The following is a description of a gene set: Human Gene Set: REACTOME_ATTACHMENT_AND_ENTRY studied in species Homo sapiens Attachment and Entry, and this is the list of marker genes: SDC4, CTSL, TMPRSS2, NRP1, GPC3, HAVCR1, FURIN (NCBI Gene Id 5123), SDC2, VCP, GPC1, ACE2, SDC1, GPC4, GPC5, SDC3, AGRN, GPC6, HSPG2 (NCBI Gene Id 7796), GPC2